The following is a description of a gene set: Human Gene Set: NAKAYAMA_SOFT_TISSUE_TUMORS_PCA1_DN species: Homo sapiens from publication Nakayama R, Nemoto T, Takahashi H, Ohta T, Kawai A, Seki K, Yoshida T, Toyama Y, Ichikawa H, Hasegawa T (PMID 17464315) In soft tissue sarcomas, the diagnosis of malignant fibrous histiocytoma (MFH) has been a very controversial issue, and MFH is now considered to be reclassified into pleomorphic subtypes of other sarcomas. To characterize MFH genetically, we used an oligonucleotide microarray to analyze gene expression in 105 samples from 10 types of soft tissue tumors. Spindle cell and pleomorphic sarcomas, such as dedifferentiated liposarcoma, myxofibrosarcoma, leiomyosarcoma, malignant peripheral nerve sheath tumor (MPNST), fibrosarcoma and MFH, showed similar gene expression patterns compared to other tumors. Samples from those five sarcoma types could be classified into respective clusters based on gene expression by excluding MFH samples. We calculated distances between MFH samples and other five sarcoma types (dedifferentiated liposarcoma, myxofibrosarcoma, leiomyosarcoma, MPNST and fibrosarcoma) based on differentially expressed genes and evaluated similarities. Three of the 21 MFH samples showed marked similarities to one of the five sarcoma types, which were supported by histological findings. Although most of the remaining 18 MFH samples showed little or no histological resemblance to one of the five sarcoma types, 12 of them showed moderate similarities in terms of gene expression. These results explain the heterogeneity of MFH and show that the majority of MFHs could be reclassified into pleomorphic subtypes of other sarcomas. Taken together, gene expression profiling could be a useful tool to unveil the difference in the underlying molecular backgrounds, which leads to a rational taxonomy and diagnosis of a diverse group of soft tissue sarcomas. Top 100 probe sets contrubuting to the negative side of the 1st principal component; predominantly associated with synovial sarcoma and myxoid/round cell liposarcoma samples., and this is the list of marker genes: LRRN2, NEFH, ADGRL1, CAPN6, TOX3, SFRP1, WIF1, SOX11, ITIH5, NELL1, RIMBP2, ACACB, ALDH5A1, ADIPOQ, COL2A1, ADGRA3 (NCBI Gene Id 166647), GPC4, PEG10, MDFI, NTRK2, EDN3, TAC1, CRABP1, KBTBD11, TLE2, GP1BB, HIP1R, CUX2, ISYNA1, MAGED4B, CACNA1G, HSD11B2, DLK1, CRLF1, ITM2C, CITED1, CAP2 (NCBI Gene Id 10486), ECHDC3, FGF18, MAGEA9, EPHX2 (epoxide hydrolase 2), TLE1, SEZ6L2, SHANK2, SIX1, FGFR3, EPB41L4B, CTAG1B, GPD1, EFNB3 (ephrin B3), RBP4, RIPK4, NDN, COL4A5, SEMA6A, IGFBP2 (NCBI Gene Id 3485), EMX2, FGFR2, RET, TRO, LPL (NCBI Gene Id 4023), NNAT, COL9A3, NFIB (nuclear factor I B), B3GAT1, GPM6B, LHX2, PRAME, OLFM1, NPTX2, RHOD, PEG3, RAC3, ZDHHC11, APBA2, PPP1R1A, SIM1